The following is a description of a gene set: studied in species Homo sapiens Human Gene Set: GSE3039_ALPHABETA_CD8_TCELL_VS_B1_BCELL_UP Three innate (B1-B, NKT, CD8aaT cells) and adaptive (B2-B, CD4T, CD8abT cells) cell-types were sorted by FACS. Three biological replicates for NKT, CD4T, CD8aaT, CD8abT cells and two biological replicates for B1 and B2 cells were generated and the expression profiles were determined using Affymetrix Mu74Av2 chip. Comparisons between the sample groups allow the identification of genes differentially expressed between the innate and adaptive cell-types. from publication Yamagata T, Benoist C, Mathis D (PMID 16623764) Genes up-regulated in CD8A CD8B versus B1 B lymphocytes., and this is the list of marker genes: ARHGAP25, GATC, ZNF770, LRP4, SHPRH, NOD1, CDK13, RAPGEF6, TMEM185A, DMRTB1, TDRD7, PPM1B, FHIP1B, TNRC6B, IPO7, RAP1GAP2, HERC1, HFE (NCBI Gene Id 3077), ELANE, ZNF638, CD33 (CD33 molecule), MDM1, LMAN1L, STX16, PURG, GPR183, AKNA, ARAP3, SH3BP5, ANGEL2, PPP4R3B, AATF, BTLA, PIGL, CYFIP2, TBPL1, RGS2, MYO9A, BMX, RESF1 (NCBI Gene Id 55196), ASB7, TIAM2, PIGC, PHIP, PRDM15, NEDD9, EPC2, DOP1A, TRIM11, TAF1C, VPS13B, FNTA, DOCK10, NLRP12, MOV10L1, KHDC4, CASD1, LIN28A, CFAP141, HCST, CACNA1S, PPDPF, TMEM131L, KBTBD3, HSD17B8, VAMP5, MLLT10, RAF1, EIF4A2 (eukaryotic translation initiation factor 4A2), LYNX1, SLC25A27, ZNF175, IKBKB, MAP3K3 (mitogen-activated protein kinase kinase kinase 3), CCPG1, SNN, DIDO1, ANAPC16, RRM2B, CDH17, CNOT8 (NCBI Gene Id 9337), DYSF, KLHL24, RNF167, KIAA0513, ACVR2A, KBTBD11, DOCK11, RPL35, ITCH, FGR, AP3M2, ZNF740, CERT1, TNRC6C, CCNL2, BLOC1S2, ELK4, MAP3K5, STAMBPL1, OGT, NSA2, KIAA0930, ARHGAP30, NAPG, ZFAND4, SPIC, NIBAN1, ZW10, CR1L, BZW2, CNR2, SYNJ1, CDC37L1, ADGRE5, MGST2, SMG1 (SMG1 nonsense mediated mRNA decay associated PI3K related kinase), SLC16A9, MAN2B1, SMAD5, MIER1, PBXIP1 (NCBI Gene Id 57326), PNPLA7, IKZF1, MIER3, GAD1, ST8SIA4, TREML2, MARF1, CASP2, RDH12, ZNF274, ITPR1, RPL18A, C4orf33, ZBTB43, UBE2G1, MS4A3, PALS2, CLIP1, STARD7, XIAP, MSL2, NXPE4, GFRA2, MARCHF3, BPGM, URI1, ANKH (NCBI Gene Id 7995), RNASE6, KXD1, MKNK2, ANKRD12, TERB1, HSD11B1, TMEM273, RNF146, NAV1, MBNL3, CKS2, GCNT2, RNF44 (NCBI Gene Id 260352), ATP2A3, MXD1, DPF3, SMARCA2, ICE1, MAU2, CCNT2, LBR, RNF2, RBM27, MFF, DHRS7, PTPRE, IRF9, NUFIP2, RCHY1, PPP1CC, PLP2, CYB5R1, CD2BP2, OMA1, ABCB1, TNKS2, GSTM2, RNF144A, DUSP6, TRAPPC5, FES (NCBI Gene Id 2242), PTBP3, CD19 (CD19 molecule), FILIP1L, HARS2, DAPP1, LRG1, ABHD13, NR2C2, SBDS, C2orf68